The following is a description of a gene set: A G protein-coupled receptor signaling pathway initiated by a dopamine binding to its receptor on the surface of a target cell, and ending with the regulation of a downstream cellular process. studied in species Homo sapiens Human Gene Set: GOBP_G_PROTEIN_COUPLED_DOPAMINE_RECEPTOR_SIGNALING_PATHWAY, and this is the list of marker genes: VPS35, GNG2, SLC1A1, GSK3A, ADCY6, FLNA, DRD5, DTNBP1, RGS9, KLF16, LRRK2, RGS8, GSK3B, CAV2, DRD1, GNAL, GNB5, NHERF1, NCSTN (NCBI Gene Id 57297), RGS4, ARRB2, C14orf28, PALM, DRD3, DRD4, PRMT5, GNAO1, GNA11, ADCY5, GNA14, ALK, GNB1, GNAS, PTGER1, DRD2